The following is a description of a gene set: The process whose specific outcome is the progression of the adrenal gland over time, from its formation to the mature structure. This gland can either be a discrete structure located bilaterally above each kidney, or a cluster of cells in the head kidney that perform the functions of the adrenal gland. In either case, this organ consists of two cells types, aminergic chromaffin cells and steroidogenic cortical cells. studied in species Homo sapiens Human Gene Set: GOBP_ADRENAL_GLAND_DEVELOPMENT, and this is the list of marker genes: NF1, WT1, WNT11, DKK3, HMGA2, SMAD3, STRA6, MDK (NCBI Gene Id 4192), PDGFRA, CRH, CRHR1 (corticotropin releasing hormone receptor 1), ARID5B, SALL1, INSM1, TSPO, NR3C1, SMAD4, NR0B1, APOA1, ASCL1 (achaete-scute family bHLH transcription factor 1), CITED2, WNT4, INSR, NR5A1, ARMC5, PBX1, CDKN1C